Given this list of marker genes Ski, Sirt4, Ing2, Ucn, Sirt6, Sirt3, Hdac6, Trp53, Hdac7, Ncor1, Sirt5, Hdac10, Sirt2, Hdac11, Mta2, Atxn3, Hdac2, Hopx, Suds3, Mapk8, Hdac3, Mier1, Mier2, Hdac1, Sirt1, Hdac9, Hdac4, Hdac8, Sirt7, Hdac5, here is a description of the gene set: Catalysis of the reaction: Removal of an acetyl group from a lysine residue in a protein. Mouse Gene Set: GOMF_PROTEIN_LYSINE_DEACETYLASE_ACTIVITY studied in species Mus musculus